Given this list of marker genes CARD8, GSTP1, APOA1, ANXA4 (NCBI Gene Id 307), PTPN2, XIAP, F2RL1, GAS6, BIRC7, TAX1BP1, MIR152, NLRP2B, ZNF675, PIAS4, MIR27B, MIR24-1, MIR125B1, TNFRSF11B, PYDC2, NOL3, ADIPOQ, RFFL, PYDC1, PELI3, TANK, GPS2, TRAIP, PPP2CB, CARD16, DICER1, CLDN18, NR1H4, MIR21, MIR130A, NAIP, H2BC11, CCDC3 (NCBI Gene Id 83643), here is a description of the gene set: species: Homo sapiens Human Gene Set: GOBP_NEGATIVE_REGULATION_OF_TUMOR_NECROSIS_FACTOR_MEDIATED_SIGNALING_PATHWAY Any process that decreases the rate or extent of the tumor necrosis factor-mediated signaling pathway. The tumor necrosis factor-mediated signaling pathway is the series of molecular signals generated as a consequence of tumor necrosis factor binding to a cell surface receptor.